Given this list of marker genes TREM2, B2M, HLA-DRB1, SEC23B, FOS, BTNL2, PTEN, BSCL2, GNAS, ZBTB20, AGPAT2, SDHD, CAVIN1, SDHC, SH3BP2, AKT1, PPARG, SDHB, TYROBP, USF3 (upstream transcription factor family member 3), NF1, VDR, PDGFRB, CAV1, NOTCH3, PRG4, KRAS, KLLN, PIK3CA, FGFR1, here is a description of the gene set: studied in species Homo sapiens A fluid filled cavity that develops with a bone. Human Gene Set: HP_BONE_CYST Bone cyst